Given this list of marker genes CLDN10, XDH, ITPR3, CLCNKA (chloride voltage-gated channel Ka), CFB, SLC12A1, AVPR2, PTPN22, ENPP1, ATP1A1, IRF5, BBS2, NPHP1 (nephrocystin 1), BSND, MT-CO3, PKHD1, CTNS, KCNJ1, SLC41A1, AGTR1, UMOD, APRT, PAX2, AQP2, MYH11, CD46, HNF1A, SEC61A1, CFHR1, SLC22A12, DMP1, CFHR3, KCNJ5, SLC12A3, CFI, SLC25A20, THBD, SARS2, CLCNKB, IL6, OBSCN, HLA-DRB1, MUC1, TMEM67, ACE, SON, KCNJ10, REN, CAV1, CASR, KL, CYP24A1, C3, LPIN1, PLVAP, CCR6, FAM20A, CFH, NEK8, DZIP1L, RYR1 (NCBI Gene Id 906), AGT, LZTFL1, SLC5A2, RRAGD, MT-CO1, NPHP3, CCN2, NPHP4, GALNT3, SLC34A1, CLDN16, PBX1, PAX4, MAGED2, here is a description of the gene set: An altered ability of the kidneys to void urine and/or specific substances. studied in species Homo sapiens Human Gene Set: HP_ABNORMALITY_OF_RENAL_EXCRETION Abnormality of renal excretion